Given this list of marker genes SCG5, SPIN4, EML4, PRDM1, ABHD2, SLC25A40, LINC01127, SERPINE1, C3orf80 (chromosome 3 open reading frame 80), CYB5D1, FRG1JP, KIAA0513, SLC16A6, AGO1, ABCD3, NAT1, CD300LB, ADO, LPXN, TXNIP, FGL2, ETHE1, GAPDH, CD84, PTGFRN, NCEH1, FAM200B, DBF4, PFKFB4, HNRNPLL, MYG1, STK38L, HMGN2, AVPI1, SNX30, S1PR3, VSIG4, PAPSS1, CLEC7A, KITLG, KCNJ5-AS1, SERPINB5, RASAL2, PPARGC1B (PPARG coactivator 1 beta), HCLS1, ALDH3A2, TUT7, STXBP1, FPR3 (NCBI Gene Id 2359), ITGB2, PRCP (NCBI Gene Id 5547), CD36 (NCBI Gene Id 948), LYPLAL1, CD226 (NCBI Gene Id 10666), CCDC102B, IRAG1, ENC1, LSP1, SQLE, ME1, SLC1A3, PINLYP, CLEC5A, MAP4K3, ACAA2, SRY, FOS, NEURL1B, BRWD1, TXNRD1, YWHAQ, KLF9, LINC00622, EPHX1, FBP1, MAP1LC3B, RGS1, SPOCD1, FABP4, IRGQ, G6PD, HPCAL1, MBNL1, AKR1C3, GPAT3, CA2, DHX32, MINPP1, DOCK10, IL13RA1, GABARAPL1, ITGB2-AS1, LRP5L, KLHL26, CPEB4, CCND1, CERK, DENND1B, DCSTAMP (dendrocyte expressed seven transmembrane protein), TRPS1, ANKRD55, FAM135A, TMEM45B, GANC, GLA, RAP1GDS1, H2BC21, NSUN3, TNFSF13B, MNDA, CYP1B1, BID, OR52K3P, CREB5, DNAH17, ITFG1, CELF2, CASS4, LST1, USP3, LINC00028, CAMSAP2, NDUFB4, LINC02035, RASSF5, SPP1, CHST11, PHKA2, NCF2, HMG20B, ITGB7, HAT1, SLC22A4, DISP1, GPR65, RNASE6, P3H2, SLC37A2, AURKA, MITF, HOMER3, PGD, SRD5A3, DEFB1, PLXDC2, ANKH, CD1A, RAB7B (NCBI Gene Id 84855), ABCA6, LPAR1, OASL, LRRK2 (leucine rich repeat kinase 2), CD1B, GJC1, C1orf54, CAMK1, SLC49A4, TAGAP, LIPA, TIGD2, BRCA2, FILIP1L, IL1RAP, UBASH3B, IL18, IL1R2, GNA13, DLC1, FN1, AP3M1, H3C12, ERRFI1, MALT1, BBS4, TBC1D23, TRMT5 (NCBI Gene Id 57570), TREM1, SLC9A9, C5AR2, HHEX, LINC-PINT, TRIM24, SCHIP1, GFOD1, CD1E, RBPJ, TM6SF1, SKAP2, ITPR1, AHCYL1, COX7B, RGCC, RAPH1, MAN1A2, POU4F2, here is a description of the gene set: species: Homo sapiens Genes down-regulated in bone marrow-derived macrophages with MLL4 knockout: control versus treated with LPS for 4h. Human Gene Set: GSE30971_CTRL_VS_LPS_STIM_MACROPHAGE_WBP7_KO_4H_DN Histone methyltransferases catalyze site-specific deposition of methyl groups, enabling recruitment of transcriptional regulators. In mammals, trimethylation of lysine 4 in histone H3, a modification localized at the transcription start sites of active genes, is catalyzed by six enzymes (SET1a and SET1b, MLL1–MLL4) whose specific functions are largely unknown. By using a genomic approach, we found that in macrophages, MLL4 (also known as Wbp7) was required for the expression of Pigp, an essential component of the GPI-GlcNAc transferase, the enzyme catalyzing the first step of glycosylphosphatidylinositol (GPI) anchor synthesis. Impaired Pigp expression in Wbp7-/- macrophages abolished GPI anchor-dependent loading of proteins on the cell membrane. Consistently, loss of GPI-anchored CD14, the coreceptor for lipopolysaccharide (LPS) and other bacterial molecules, markedly attenuated LPS-triggered intracellular signals and gene expression changes. These data link a histone-modifying enzyme to a biosynthetic pathway and indicate a specialized biological role for Wbp7 in macrophage function and antimicrobial response. from publication Austenaa L, Barozzi I, Chronowska A, Termanini A, Ostuni R, Prosperini E, Stewart AF, Testa G, Natoli G (PMID 22483804)